Given this list of marker genes RSC1A1, PKDCC, LYPLAL1 (lysophospholipase like 1), LYPLA1, ANXA13, CSK, here is a description of the gene set: Human Gene Set: GOBP_NEGATIVE_REGULATION_OF_GOLGI_TO_PLASMA_MEMBRANE_PROTEIN_TRANSPORT studied in species Homo sapiens Any process that stops, prevents, or reduces the frequency, rate or extent of the transport of proteins from the Golgi to the plasma membrane.